The following is a description of a gene set: Childhood acute lymphoblastic leukemia (ALL) is curable with chemotherapy in approximately 80 percent of patients. However, the cause of treatment failure in the remaining 20 percent of patients is largely unknown. from publication Holleman A, Cheok MH, den Boer ML, Yang W, Veerman AJ, Kazemier KM, Pei D, Cheng C, Pui CH, Relling MV, Janka-Schaub GE, Pieters R, Evans WE (PMID 15295046) Human Gene Set: HOLLEMAN_ASPARAGINASE_RESISTANCE_B_ALL_DN Genes distinguishing asparaginase resistant and sensitive B-lineage ALL; here - genes down-regulated in the drug resistant samples. species: Homo sapiens, and this is the list of marker genes: RAP2C, UBE2Z, H2BC12, DERL2, H2BC12L, JUP, ARRB2, MAPK1IP1L, ELK3, CCNG2, MAN1A1, ARF6, RAB5C, ADGRG1, F8A1, ZNF318